The following is a description of a gene set: studied in species Homo sapiens There is evidence that the vasculature of different organs display different functional characteristics in response to cytokines and growth factors. The aim of this study was to use cDNA gene expression microarray to analyse changes in gene expression following stimulation of myometrial microvascular endothelial cells (MMECs) with vascular endothelial growth factor (VEGF). Primary isolates of MMECs were obtained from fresh hysterectomy specimens and purified with magnetic beads. Cells were stimulated with 15 ng/ml VEGF for 3, 6 and 12 h, and two unstimulated experiments served as controls. A total of six arrays was performed over these time-points. A total of genes were identified as up-regulated by VEGF, 19% of which (genes) have previously been reported as up-regulated by VEGF or by angiogenesis. Among the novel genes to be up-regulated by VEGF were brain-derived growth factor, oxytocin receptor and estrogen sulphotransferase. The significance of the genes identified in the physiological and pathological functioning of the myometrial vasculature is discussed. from publication Weston GC, Haviv I, Rogers PA (PMID 12200464) Human Gene Set: WESTON_VEGFA_TARGETS_6HR Genes up-regulated in MMEC cells (myometrial endothelium) at 6 h after VEGFA stimulation., and this is the list of marker genes: ELN, GSTT1, COL6A3, FGFBP1, COL1A2, POSTN, MMP2, CCL7, NNMT (NCBI Gene Id 4837), SLC49A4, SULT1E1, BMP4, BGN, NID2, PVALB, MEST (mesoderm specific transcript), SEMA5A, SLC6A8, HTR2B, CCL2, ROR2, SP3, C1S, UNG, THY1, KRT18, ANKRD1, FHL3, GJA4, BDNF, COL6A1, VCAN, BCKDHA, ART4, SGCE, ESR1, ADORA2B, GEM, ISL1 (ISL LIM homeobox 1), MGP, TFPI2 (tissue factor pathway inhibitor 2), FBP1, SAT1, TNFSF10, SHC3, CFHR1, SDC4, AQP7, FAP, OXTR